The following is a description of a gene set: from publication Bauer AK, Rondini EA, Hummel KA, Degraff LM, Walker C, Jedlicka AE, Kleeberger SR (PMID 21543283) We previously identified toll-like receptor 4 (Tlr4) as a candidate gene responsible for ozone (O3)-induced pulmonary hyperpermeability and inflammation. The objective of this study was to determine the mechanism through which TLR4 modulates O3-induced pulmonary responses and to utilize transcriptomics to determine TLR4 effector molecules. C3H/HeJ (HeJ; Tlr4 mutant) and C3H/HeOuJ (OuJ; Tlr4 normal), mice were exposed continuously to 0.3 ppm O3 or filtered air for 6, 24, 48 or 72 hr. Affymetrix Mouse430A_MOE gene arrays were used to analyze lung homogenates from HeJ and OuJ mice followed using a bioinformatic analysis. Inflammation was assessed by bronchoalveolar lavage and molecular analysis by ELISA, immunoblotting, and transcription factor activity. TLR4 signals through both the MYD88-dependent and independent pathways in OuJ mice, which involves MAP kinase activation, NF-kappaB, AP-1, and KC. Microarray analyses identifiedTLR4 responsive genes for strain and time in OuJ versus HeJ mice (p<0.05). One significantly upregulated cluster of genes in OuJ were the heat shock proteins (Hspa1b; Hsp70), Hsp90ab1). Furthermore, O3-induced expression of HSP70 protein was increased in OuJ compared to HeJ mice following 24-48 h O3. Moreover, BAL polymorphonuclear leukocytes (PMN) and total protein were significantly reduced in response to O3 in Hspa1a/Hspa1btm1Dix (Hsp70-/-) compared to Hsp70+/+ mice (p<0.05). TLR4 signaling (MYD88-dependent), ERK1/2, AP-1 activity, and KC protein content were also significantly reduced after O3 exposure in Hsp70-/- compared to Hsp70+/+ mice (p<0.05). These studies suggest that HSP70 is involved in the regulation of O3-induced lung inflammation through the TLR4 pathway and provide evidence that HSP70 is an endogenous in vivo TLR4 ligand. species: Homo sapiens Genes up-regulated in comparison of lung tissue from wild type mice subjected to ozone for 0 h versus that from wild type mice subjected to ozone for 24 h. Human Gene Set: GSE20715_0H_VS_24H_OZONE_LUNG_UP, and this is the list of marker genes: TCEA3, RAMP1, TMEFF1, BEX2, PDGFA, SERTAD2, PKP2, RAC2, ZMYM4, GNG10, CA2, MMP11, KCNH2, SLFN12, PACS1, TCF7, HPS3, EMP2, DCTN6, TGFB2, SERPINB1, CAMK2G, YPEL5, RNF138, IGKC, PIGP, TCTA, GNB4, CYTH3, QNG1, TLCD2, TMED4, MDM1, PMPCB, CRIP1, HADH, TMOD3 (tropomodulin 3), LMO2, IFT46, TANC1, ETS1, TRADD, RGS2, RTN1, NCR1, ADCY8, MAP4K1, ARMCX1, PLCG2, PLSCR3, THEMIS2, ARHGEF2, HMGB2, TNFSF10, CDH5, CIZ1 (CDKN1A interacting zinc finger protein 1), POLR3C, ZBTB22, S100A8, PITPNM1, EVL, HLA-B, MPP1, RASGRF2, RMND5B, SLC6A6, MRPS35, GATC, SATB1, BCAS3 (BCAS3 microtubule associated cell migration factor), PTPRS, LSP1 (lymphocyte specific protein 1), S100A9 (NCBI Gene Id 6280), MYLIP, NRP2, EPHA1, CSRP1, ICAM2, RIPOR2, NREP, AHSP, FMNL3, FIG4, IKBKB, IRS1, RHPN2, MPDU1, LRRC56, NUP42, XCL1, CD19, OAZ2, MGLL (monoglyceride lipase), ST8SIA4, DYNLRB1, TBX2, SLC38A5, CLEC7A, HACD4, MRPL27, PTPRC, ELK3, BABAM1, SHISA5, CCR2, MEOX2, SPRYD3, ADPRM, HNRNPR (NCBI Gene Id 10236), USHBP1, TRPV2, NHSL1, RFX5, TRIM21, LIMD2, CD2, PRDM1, LXN, SCN7A, RALB, CCL5, SLC40A1, CDKN2C, FCRL1, HCFC1, SPNS2, RPA3, ALDH7A1, GAB1, ATRAID, CYB5R3, MPND, ARL16, DNAJC8, PPT1, PPP2R3A (protein phosphatase 2 regulatory subunit B''alpha), ADRB1, CD27, EPB41L5, TK2, RIOK1, PRODH, HHIP, CORO1A, ANAPC2, SELL, SMIM14, CD53, GNG11, SEPTIN10, PTGER2, SNX2, MYO1G, MYO1F, PECAM1, CD7, HFE, BACH2, ANP32A, PDCD4, FHDC1, CXCR4, HCST, PARP12, CD3G, CD36, RASA3, HMG20A, DGKZ, CASP8, RAI1, SEMA4D, IL2RG, NUP210, KDR, NIT1, REEP3, FZD2, PPFIBP2, BAG6, SQOR, ARAP2, PLEKHA6, ARHGAP1, FERMT3, PRKCB, HS2ST1, ARHGDIB, STMP1, JPT1, GASK1B, CDC42SE2 (NCBI Gene Id 56990), MS4A6A, BTRC, FOXP1, TYROBP, TSPAN13, NCF4, CD6, FXYD1